Given this list of marker genes BTNL2, PSD3, PEA15, AFF3 (NCBI Gene Id 3899), S100A4, DOCK2, MYO7B, TXNIP, INHBC, APOF, LDAF1, ZMAT3, TMEM45B, JAK3, LEFTY2, PRSS42P, EXT2, FHIT, TWIST1, RPE65, SLCO1C1, EFNA4, CCDC183, LCP2, AIRN, RHOH, BICDL1, PRSS56, WASF3, LGALS3, ATP2B2, ZSWIM5, RPS8, PTP4A3, FREM1, SLC25A22, AGTR1, HMGA2, SGCB, VAMP8, MBNL1, CYP4A11, TNFSF4, TBX20, CDH16, HS3ST1, C3orf22, TSPY1, HOXB13, CCNG1, CIMIP6, RADIL, VTCN1, SAP30L, TVP23A, RCHY1, HMBOX1, RPL23A, SIRT2, AIRE, ERCC5, CNST, ACSBG1, PRR22, NMBR, ADRA2B, PARP9, PROM1, USP26, POMGNT1, GRHL3 (grainyhead like transcription factor 3), TMEM104, DYNLL2, TPST1, CKB, YWHAB, SSU72, COMMD5, NKD1, CRYBA1, HPCAL1, EXOC5, PHLDA3, SV2A, ZBTB9, BCL2A1, MST1, PPM1H, CDC42BPG, GBA1, ZNF148 (zinc finger protein 148), BTG3, MIOX, LOXL2, KLRD1, RMC1, GSTT1, ANKRD9, CXXC5, IRS4, RSPO3, SHC4, TNS4, HMCES, PRR32, GPR83, ASS1, SCARB2 (scavenger receptor class B member 2), CPQ, HCN3, SAMSN1, GAL3ST4, GPX8, PGLYRP1, CIB4, LRGUK, TNRC6A, GIMAP4, HSD17B11, STMN4, CLCN4, PENK, ZNF365, IER5, ST14, MRRF, TPR, ZKSCAN4, CPS1, LPL, AUTS2, NALCN, HTR1D, SLC35F3, C16orf90, ANPEP, RAP1GAP, LYST, CYP39A1, UBTF, NGF, PDLIM2, HCFC1R1, SLC17A6, NME5 (NCBI Gene Id 8382), TBC1D10C, CCDC88B, CCDC198, GPR37L1, BATF2, UNC5CL, H2AC18, ADIPOQ, SCARF1, KRTAP7-1, TMPRSS15, SLC24A2, C12orf56, SLC8B1, SORL1, RNF180, SGSM2, CTSE, KLHL14, TTLL5, COBL (NCBI Gene Id 23242), CARTPT, DCLK1, RPTN, PLEKHG1, SYNC, SHLD2, UBC, PLK3, S100A11, CIB3, GZMB, ZMAT5, GRAMD1B, VPS53, SLC6A12, SELENOP, TRAPPC12, ORM1, OS9, SNX1, NT5E, NAA20, TOM1L1, STAM2 (signal transducing adaptor molecule 2), EPHX1, FUT7, RNF125, CSRNP1, ITPKC, TOX, MED10, TRHDE, MAP1LC3B, RSPH14, here is a description of the gene set: Genes down-regulated in B lymphocytes: control versus stimulated by anti-IgM for 16h. Human Gene Set: GSE21063_CTRL_VS_ANTI_IGM_STIM_BCELL_16H_DN studied in species Homo sapiens from publication Bhattacharyya S, Deb J, Patra AK, Thuy Pham DA, Chen W, Vaeth M, Berberich-Siebelt F, Klein-Hessling S, Lamperti ED, Reifenberg K, Jellusova J, Schweizer A, Nitschke L, Leich E, Rosenwald A, Brunner C, Engelmann S, Bommhardt U, Avots A, Müller MR, Kondo E, Serfling E (PMID 21464221) Triggering of B cell receptors (BCR) induces a massive synthesis of NFATc1 in splenic B cells. By inactivating the Nfatc1 gene and re-expressing NFATc1 we show that NFATc1 levels are critical for the survival of splenic B cells upon BCR stimulation. NFATc1 ablation led to decreased BCR-induced Ca++ flux and proliferation of splenic B cells, increased apoptosis and suppressed germinal centre formation and immunoglobulin class switch by T cell-independent antigens. By controlling IL-10 synthesis in B cells, NFATc1 supported the proliferation and IL-2 synthesis of T cells in vitro and appeared to contribute to the mild clinical course of Experimental Autoimmune Encephalomyelitis in mice bearing NFATc1-/- B cells. These data indicate NFATc1 as a key factor controlling B cell function.